Given this list of marker genes Calm3, Gstm7, Calm1, Nol3, Camk2d, Mettl21c, Tmem38a, Trdn, Dhrs7c, Chd7, Hrc, Pln, Gsto1, Slc8a1, Calm2, Ryr2, Pde4d, Ank2, Fkbp1b, Casq1, Cacna1c, Casq2, Tmem38b, Dmd, here is a description of the gene set: Any process that modulates the rate, frequency or extent of release of sequestered calcium ion into cytosol by the sarcoplasmic reticulum, the process in which the release of sequestered calcium ion by sarcoplasmic reticulum into cytosol occurs via calcium release channels. Mouse Gene Set: GOBP_REGULATION_OF_RELEASE_OF_SEQUESTERED_CALCIUM_ION_INTO_CYTOSOL_BY_SARCOPLASMIC_RETICULUM species: Mus musculus